The following is a description of a gene set: Human Gene Set: GOBP_NEGATIVE_REGULATION_OF_CALCIUM_ION_EXPORT_ACROSS_PLASMA_MEMBRANE studied in species Homo sapiens Any process that stops, prevents or reduces the frequency, rate or extent of calcium ion export across the plasma membrane., and this is the list of marker genes: CALM3, CALM1, YWHAE, CALM2, MIR1-1